The following is a description of a gene set: studied in species Homo sapiens Human Gene Set: GOBP_NEGATIVE_REGULATION_OF_INTERLEUKIN_6_MEDIATED_SIGNALING_PATHWAY Any process that decreases the rate, frequency or extent of an interleukin-6-mediated signaling pathway., and this is the list of marker genes: IL6ST, MIRLET7C, MIR125A, MIRLET7E, MIR146A, MIR26A1, MIR99A, MIR125B1, MIR98, PTPN2, MIRLET7A1